The following is a description of a gene set: species: Homo sapiens Human Gene Set: MIR509_5P Genes predicted to be targets of miRBase v22 microRNA hsa-miR-509-5p in miRDB v6.0 with MirTarget v4 prediction scores > 80 (high confidence targets). from publication Chen Y, Wang X (PMID 31504780), and this is the list of marker genes: TNPO1, C5orf24, TARDBP, TNFRSF19, OGFRL1, TENM1, SCAMP1, ANKRD50 (NCBI Gene Id 57182), ANLN, SLC25A5, MED28, GPALPP1, MED13L, CCSER2 (NCBI Gene Id 54462), SERTAD2 (SERTA domain containing 2), CSMD2, INO80D, MPC1, ACBD3, GALC, EIF1B, TMEM209, CAMK2D, KHDC4, SYN2, NUP35, PIEZO2, NFXL1, EPB41, DENND6A, NOS1, HNF1B, CAMTA1, SHISA9, JARID2, OCM2, OCM, MXRA5, GTF2IRD2B, GFOD1, SLC25A38, DISC1, CDC14A, ATP9B, WAPL, SNX27, SLC9A7, TP53TG3C, TET1, EZH2, CIMIP6, IQCH, TDG, NCAM1, CCNJ, SYNGR2, SLC38A2, AGFG1, NDN, ATXN7, ACSL6, ANKMY2, PPM1F, CHRNE, GID8 (GID complex subunit 8 homolog), G3BP2, CTNNB1, TIAM2, SHROOM1, CALD1, GOLGA1, TP53TG3D, EIF5B, ARF6, POLR3F, TP53TG3B, CORO1C, NUDT7, SLC38A9, KIAA0232, GTF2IRD2, ZHX1, FGF2, HSPA9, RAP2C, PGRMC1, TRAPPC2, RAB37, SNED1, PROX1, ZNF423, EPHA6, PIP4K2B, IPO8, NES, CD200R1, LILRB1, ZFAND5, PTPRZ1, COL6A6, MTMR8, IP6K3, LDB3, SLC1A1 (solute carrier family 1 member 1), CSTF2, AFF3, PAFAH2, EHD4, CELA1, KIF5C, TOGARAM1, PSIP1, WDFY1, SINHCAF, GPM6A, IGF1R, ESRRG, HYCC2, HACD3, GARIN6, RAB11A, NHEJ1, NFAT5, GPR85, ELP3, E2F7, OGG1 (NCBI Gene Id 93577), ACLY, NLGN1, ATAD2B, RNGTT, ELOC (NCBI Gene Id 6921), P2RY10, GATB, RTKN2, SLC2A10, RHOT1, FIGN, BTG1, WNK3, TRAK1, PICALM, MGAT4A, G6PC1, FAM168B, SLC4A2, ZPLD1, BCL11A, AP3M1, EIF4E2, SMC2, MBOAT2, PSTPIP2, SPOPL, RNF139, KDM4A, RETREG1, DOCK3, GMFB, DCLK1, ATP11C, TP53TG3, WDR82, SYNJ2BP, POGLUT2, CLSPN, USP15, CKLF, TMEM26 (transmembrane protein 26)